Given this list of marker genes MT1E, MT1H, MT4, MT2A (metallothionein 2A), MT1M, MT1X (NCBI Gene Id 82523), MT3, MT1G, MT1A, MT1F, MT1B, here is a description of the gene set: Reactome Pathway: Metallothioneins bind metals studied in species Homo sapiens part of: Response to metal ions Metallothioneins are highly conserved, cysteine-rich proteins that bind metals via thiolate bonds (recent general reviews in Capdevila et al. 2012, Blindauer et al. 2014, reviews of mammalian metallothioneins in Miles et al. 2000, Maret 2011, Vasak and Meloni 2011, Thirumoorthy et al. 2001, Babula et al. 2012). Mammals contain 4 general metallothionein isoforms (MT1,2,3,4). The MT1 isoform has radiated in primates to 8 or 9 functional proteins (depending on classification of MT1L). Each mammalian metallothionein binds a total of 7 divalent metal ions in two clusters, the alpha and beta clusters. Though the functions of metallothioneins have not been fully elucidated, they appear to participate in detoxifying heavy metals, storing and transporting zinc, and redox biochemistry. Metallothioneins interact with many other cellular proteins, with most interactions involving proteins of the central nervous system.